Given this list of marker genes CELF4, SCAND1, IRS1, NEUROD1, SCRG1, POLR1B, GPM6B, CYP2A6, RIN2, GCM2, IGF1R, CXCL14, SPOCK2, CFHR2, GABRR2 (NCBI Gene Id 2570), NKX2-2, INCA1, COL19A1, FGF6, SCN7A, MCAM, TGM2, MDN1, TWSG1, GNAO1, MSX1, STRA6, PHLDA3, TM2D3, GDAP1, P2RX4, ADAM7, CADM1, TM4SF1, PLA2G10, ENPP2, CPSF2, ACSL1, PTPN12 (protein tyrosine phosphatase non-receptor type 12), GDNF (glial cell derived neurotrophic factor), ERCC5, SLC30A1, POU2F1, CARM1, CHL1, GPLD1, EFNB3, F2RL1, SUB1, ACADVL, AARD, NELFE, AOPEP, IRF6, FRK, NCAN, RHAG, MTRF1L, TM2D1, CELA1, PAWR, NR4A2, H3C7, PRXL2A, TUG1 (taurine up-regulated 1), IFIH1, MAGEL2, H19, NDUFA13, SSBP2, KCTD12, LIN9, CKMT2, AGAP1, HTRA2, TNFRSF9, ZNF239, LCLAT1, HAPSTR1, CCRL2, DDIT4, HINFP, NAP1L2, PBDC1, DUSP6, SLC7A11, H1-4, GSTO1, SYT1, GTF3C4, PLEKHA1, DFFA, BET1, VAMP7, PER2, ZNF35 (NCBI Gene Id 7584), SCAMP1, GSTM3, AFP, VCAM1 (vascular cell adhesion molecule 1), GCSAM, IMMT, CRISP2, POLR2C, HLA-DMA, SIX1, GMCL1, RXYLT1, TBX15, APP, METAP2, NKIRAS1, PIK3C2G, CD244, KIAA1217, TERF1, PCLO, COPRS, UQCC5, DPP7, AHR (aryl hydrocarbon receptor), CXCL13, ANXA3, SPRED2, GATA2, NOTCH4 (NCBI Gene Id 4855), RGS16, EFS, TMEM150A, NEFH, MAP2 (NCBI Gene Id 4133), PHLDB2, ATP5MF, CLDN11, CPA3, PTK6, SLC6A4, WLS, EXOSC8, KANSL2, KCNAB1, EOMES, CFH, CLCA1, MITF, SCN1A, YAP1, MYO6, LHCGR, SLC12A2, HMGA2 (NCBI Gene Id 8091), MRPS2, HOXC6, CSF1, EVI5, PNRC1, OVGP1, AUH, ABCG1, COCH, DOCK7, RGS10, FHL1, CANX, PAX1, SPP1, EPCAM, REXO5, TCF4 (transcription factor 4), ZFP28, NFIB, CD22, PTGER2, MRPL48, SMAD1, TAPBP, NSDHL, HAO2, SLX9, RBM15, ADGRG1, RFLNB, ZRANB1, PTPRJ, MAP1S, CYP4V2, EIF2AK2, EGR2, SPOUT1, NQO1, ZNF821, TLR7, TNFRSF4, IL1A, TRPC1, WFS1, ZNRF1, RPRD1B, NRK, ATP2A2, here is a description of the gene set: from publication Wherry EJ, Ha SJ, Kaech SM, Haining WN, Sarkar S, Kalia V, Subramaniam S, Blattman JN, Barber DL, Ahmed R (PMID 17950003) CD8 T cells normally differentiate from resting naïve T cells into function effector and then memory CD8 T cells following acute infections. During chronic viral infections, however, virus-specific CD8 T cells often become exhausted. We used microarrays to examine the gene expression differences between naive, effector, memory and exhausted virus-specific CD8 T cells following lymphocytic choriomeningitis virus infection. Human Gene Set: GSE9650_EFFECTOR_VS_EXHAUSTED_CD8_TCELL_DN Genes down-regulated in comparison of effector CD8 T cells versus exhausted CD8 T cells. studied in species Homo sapiens